The following is a description of a gene set: Mouse Gene Set: CUI_MONOCYTE_IFNG_RESPONSE_DN Genes negatively differentially expressed in cell type: Monocyte upon treatment with cytokine: IFN-γ in mouse lymph nodes in vivo. species: Mus musculus from publication Cui A, Huang T, Li S, Ma A, Pérez JL, Sander C, Keskin DB, Wu CJ, Fraenkel E, Hacohen N (PMID 38057668) Cytokines mediate cell-cell communication in the immune system and represent important therapeutic targets. A myriad of studies have highlighted their central role in immune function, yet we lack a global view of the cellular responses of each immune cell type to each cytokine. To address this gap, the authors created the Immune Dictionary, a compendium of single-cell transcriptomic profiles of more than 17 immune cell types in response to each of 86 cytokines (>1,400 cytokine-cell type combinations) in mouse lymph nodes in vivo. A cytokine-centric view of the dictionary revealed that most cytokines induce highly cell-type-specific responses. For example, the inflammatory cytokine interleukin-1β induces distinct gene programmes in almost every cell type. A cell-type-centric view of the dictionary identified more than 66 cytokine-driven cellular polarization states across immune cell types, including previously uncharacterized states such as an interleukin-18-induced polyfunctional natural killer cell state., and this is the list of marker genes: Eef2, Ccl9, Tmem176b, Cx3cr1, Eef1b2, Eef1a1, Fau, Naca, Lyz2, Clec4a3, Tgfbi, Ifngr1